The following is a description of a gene set: from publication Chen Y, Wang X (PMID 31504780) Genes predicted to be targets of miRBase v22 microRNA mmu_miR_6948_5p in miRDB v6.0 with MirTarget v4 prediction scores > 80 (high confidence targets). Mouse Gene Set: MIR_6948_5P species: Mus musculus, and this is the list of marker genes: Uox, Srgap2, Grm8, Atp1a3, Srsf1 (NCBI Gene Id 70724), Mylk4, Or8b53, Ppp4r3a, Map3k12, Bnc2, Pgrmc1, Med23, Mtmr4, Stxbp5l, Lbh, Zfp704, Unc5d, Dgkk (NCBI Gene Id 331374), Mmd, Mpc2, Ces1g, Abi2, Mgat4a, Ajap1, Ncoa2, Il21, Tmed7 (NCBI Gene Id 76112), Lrsam1, Tubb2b, Prickle2, Mctp2, Lamp3, Hdac9, Fmn2, Zc3h12c, Chd9 (chromodomain helicase DNA binding protein 9), Chuk, Mrpl41, Cul2, Etfdh, Tmco1, Ero1b, Whrn, Acy3, Ywhaq, Tmem87b, Zbtb6, Zfp275, Ywhab, Btf3l4, Scarf1, Krtap6-5, Ptpn20, Taf5, Melk, Mroh9, Gimap6, Marchf5, Brd7, Fut9, Akt3, Uimc1, Zmat3, Slc7a1, Plagl2, Glb1l, Wsb1, Myadm, Arhgap29, Slc25a32, Etnk2, Osbpl11, Lypd6, Crkl, Wdr72, Sulf1, Prrt2, Greb1l (NCBI Gene Id 381157), Lrrc3b, Cers6, Kif5c, Zfyve26, Hnrnpa0, Eif1ad, Taok1, Mrpl11, Lnpep, Ccdc85a, Ftcd, Kctd10, Acbd3, Map1b, Pdha1, Mlh3, Tsc22d1, Smim14, Trpd52l3, Pag1